The following is a description of a gene set: The process whose specific outcome is the progression of the enteric nervous system over time, from its formation to the mature structure. The enteric nervous system is composed of two ganglionated neural plexuses in the gut wall which form one of the three major divisions of the autonomic nervous system. The enteric nervous system innervates the gastrointestinal tract, the pancreas, and the gallbladder. It contains sensory neurons, interneurons, and motor neurons. Thus the circuitry can autonomously sense the tension and the chemical environment in the gut and regulate blood vessel tone, motility, secretions, and fluid transport. The system is itself governed by the central nervous system and receives both parasympathetic and sympathetic innervation. Mouse Gene Set: GOBP_ENTERIC_NERVOUS_SYSTEM_DEVELOPMENT species: Mus musculus, and this is the list of marker genes: Gdnf, Ret, Hlx, Sox10, Ednrb, Ednra, Tlx2, Phactr4, Slc6a4, Pds5a, Sox8 (NCBI Gene Id 20681), Phox2b, Kif26a, Ntf3, Ascl1